The following is a description of a gene set: The progression of the septum primum over time, from its formation to the mature structure. species: Homo sapiens Human Gene Set: GOBP_SEPTUM_PRIMUM_DEVELOPMENT, and this is the list of marker genes: NSD2, ACVR1, TGFB2, GJA5, SOX4, GATA4